Given this list of marker genes FOXC2, WEE1, THBD, RHOB, ARL4C, NR4A2, IL6, SGK1, TSC22D1, DNAJB4, ERRFI1, LITAF, CEBPD, PHLDA1, IRS2, MAFF, DLX2, UNC45A, SLC25A25, PER1, IER3, VEGFA, DUSP2, FOSL2, NFIL3, CEBPB, BAG3, ELL2 (elongation factor for RNA polymerase II 2), ID3, CCN2, ETS2, here is a description of the gene set: species: Mus musculus from publication Burton GR, Nagarajan R, Peterson CA, McGehee RE Jr (PMID 15033539) During cellular differentiation and development, it is recognized that many complex molecular mechanisms as well as precise patterns of differentially expressed genes occur in directing precursor cells toward a given lineage. Using microarray-based technology, we examined gene expression across the course of 3T3-L1 adipocyte differentiation. Total cellular RNA was isolated at times 0, 2, 8, 16, 24, 48, and 96 h following treatment with either standard hormonal inducers of differentiation; insulin, dexamethasone, isobutylmethylxanthine (IDX), or IDX plus trichostatin A (TsA), a histone deacetylase inhibitor and potent adipogenic inhibitor. cRNA was synthesized from cellular RNA and hybridized to high density Affymetrix MG_U74Av2 microarray gene chips containing 12,488 cDNA/Expressed Sequence Tags (ESTs) probe sets. From the IDX-only treated cells, all probe sets that were either unchanged or differentially expressed less than 2-fold throughout differentiation with respect to time 0 preadipocytes were excluded from further analyses. This selection resulted in a net of 1686 transcripts, 859 were increased in expression, and 827 were decreased in expression at least 2-fold across differentiation. To focus in on genes that were more specific to differentiation, the same analysis was performed on IDX plus TsA-treated non-differentiating cells and all probe sets from the IDX-only group that exhibited similar expression profiles in the non-differentiating TsA-treated group were excluded leaving a total of 1016 transcripts that were regulated only under differentiating conditions. Six hundred and thirty-six of these transcripts were elevated at least 2-fold and 380 exhibited a decrease in expression relative to time 0 preadipocytes. This group of genes was further analyzed using hierarchical clustering and self-organizing maps and resulted in the identification of numerous genes not previously known to be regulated during adipocyte differentiation. Many of these genes may well represent novel adipogenic mediators and markers of adipogenesis. Strongly up-regulated at 2 h during differentiation of 3T3-L1 cells (fibroblast) into adipocytes. Human Gene Set: BURTON_ADIPOGENESIS_1